The following is a description of a gene set: species: Homo sapiens Human Gene Set: SMAD3_Q6 Genes having at least one occurrence of the motif TGTCTGTCT in the regions spanning 4 kb centered on their transcription starting sites. This matches the SMAD3 transcription factor binding site V$SMAD3_Q6 (v7.4 TRANSFAC)., and this is the list of marker genes: SPECC1, CACNB2, C1orf21 (NCBI Gene Id 81563), HOXC4, ESRRG, MEIS1, NLGN2, EPB41, HCRT, ACKR1, LIMD2, TIMP4, ELOVL1, KDM3A, RFX5, SHANK1, H1-0, RAI1, KIAA1191, PLCXD2, ABHD15, PLPP7, CHDH (NCBI Gene Id 55349), TLX1, PTPN6, ERG, EYA1 (NCBI Gene Id 2138), FAP, PFKFB1, ZMYND8, FZD1, PAGR1, KIRREL1, TGIF2, TP53I13, LOX, FAM117A, ATP6V1E2, PDE4D, JADE2, YBX3, EBF1, CHD2, WNT8B, FOXB1, ASB2, FGF7, BAMBI, TMEM79, PELI3, GRIN2D, RIMS1, PPP3CB, APBB2, SRCIN1, HMGB1, PITX3, SAV1, ASAP1, MTCL2, HOXC6, MYT1, CHRM1, WNT10B, ZHX2, OLIG3, DMPK, POU2AF2, CLTC, MFAP4, ATXN7L1, NAT8L, PURA, LCOR, POU3F4, C2orf66, SYNPO, CDK5 (NCBI Gene Id 1020), LIN28A, CELF3, EPHX4 (NCBI Gene Id 253152), MRC2, MYCL, STX16 (NCBI Gene Id 8675), COL11A2, PAX2, LRRFIP1, ITIH3, SOX14, ST6GALNAC5, CGRRF1, TFDP2, PABPC5, R3HDML, MSS51, RLIM, NRXN3, AGPAT4, NYX, PIK3R3, SLC6A9, IL17RB, CDKN1A, IRX5, ACKR3, DCTN2, NOS3, FRY, AJUBA, FGF11, BCL9L (NCBI Gene Id 283149), CCDC33, MARCKSL1, NR2F2 (nuclear receptor subfamily 2 group F member 2), LTBP1, SMTN, TSHZ3, RELCH, JARID2 (jumonji and AT-rich interaction domain containing 2), RASL11B, THBS2, HOXB1 (homeobox B1), DUSP3, LUC7L3, SSBP3, ZEB2, POU4F1, B3GALT2, NNAT, ANXA9, C1QTNF5, BZW2, C1QB, ZNF654, NKX2-1, PTGR3, MORF4L2, GPC3, RNF19B, KLF7, BAZ2A, KCNJ8, CRABP2, ANKMY2, MAP2, PRLHR, BTBD3, OTX2, TFAP2D, ZDHHC22, ARID1A, PLEKHH2, NXPH4, DRC3, ALDH4A1, SMAD6, CBFA2T3, PLEKHA6, JMJD1C, SKIL, ARHGEF19, NDUFS2, LHX6, EYA4, DLX3, TOP1, EIF3J, HMCN1, SMPX, NECTIN1, SCRG1, TMEM256 (NCBI Gene Id 254863), CEACAM19, ANKS1B, TGFB2, MTMR4, ANKS6, S100A14, SMG5, BMPR2, PAX3, SIPA1, ADAMTSL2 (ADAMTS like 2), PAK3, MAP7D1, FGF23, GIT1 (NCBI Gene Id 28964), LRP2, HAPLN2, C11orf87, FAM110D, PTPN7, NTRK3, NDUFA4L2, FOXP1, GABRE, CCDC140, HES7, TMEM164, SKP1, RARB, FGF14, CSF3, TXNDC12, S100A16, MN1, ZRANB1, ITGAE, RUSC1, SYT7, CLDN16, DENND2B, RFX4, FXR1, BHLHE41, AGER, SERINC2, LAMC2, CPNE6, GADD45G, HTN1, CACNB3, CNTFR, PDLIM2, TAF6L, CRAT, EDA, SIAH3, TEAD3, CHST9, HS3ST2, EDN1, CDK5R2, ACVR1, SLC4A2, DOCK9 (NCBI Gene Id 23348), EMID1, NIN, ACTN2, KCTD15, CABP2, MIR9-1HG